Given this list of marker genes SIX3, ALX4, PPP1R12A, TONSL, PDGFRB, here is a description of the gene set: species: Homo sapiens Absence of the nasal bone. Aplasia of the nasal bone Human Gene Set: HP_APLASIA_OF_THE_NASAL_BONE